Given this list of marker genes ENSG00000297460, COMMD9, EHF, THEM7P, FJX1, LINC02721, PAUPAR, MIR3973, FBXO3, RPL29P23, SLC1A2, PRRG4, C11orf91, APIP, WT1-AS, HNRNPA3P9, CSTF3, KRT18P14, CD44-DT, EIF4A2P5, PAX6, RCN1, CCDC73, ELF5 (E74 like ETS transcription factor 5), ENSG00000295952, ABTB2, LDLRAD3, MIR1343, WEE2P1, LINC03031, FBXO3-DT, DNAJC24, SPICP1, EIF3M, QSER1, TCP11L1, CYCSP25, CAPRIN1, IMMP1L, ENSG00000286626, RPL12P31, LMO2, KIAA1549L, PDHX, TRIM44, SLC1A2-AS2, PRR5L, PAMR1, ENSG00000255375, PIGCP1, WT1, LINC00294, CIR1P3, CD44, CD44-AS1, DEPDC7, DCDC1, CAT, ENSG00000212551, SLC1A2-AS1, ELP4, HIPK3, MMADHCP2, NAT10, CD59, LINC02707, CSTF3-DT, here is a description of the gene set: species: Homo sapiens Human Gene Set: chr11p13